The following is a description of a gene set: Hematopoietic stem cells (HSCs) have self-renewal capacity and multilineage developmental potentials. The molecular mechanisms that control the self-renewal of HSCs are still largely unknown. Here, a systematic approach using bioinformatics and array hybridization techniques to analyze gene expression profiles in HSCs is described. To enrich mRNAs predominantly expressed in uncommitted cell lineages, 54 000 cDNA clones generated from a highly enriched population of HSCs and a mixed population of stem and early multipotent progenitor (MPP) cells were arrayed on nylon membranes (macroarray or high-density array), and subtracted with cDNA probes derived from mature lineage cells including spleen, thymus, and bone marrow. Five thousand cDNA clones with very low hybridization signals were selected for sequencing and further analysis using microarrays on glass slides. Two populations of cells, HSCs and MPP cells, were compared for differential gene expression using microarray analysis. HSCs have the ability to self-renew, while MPP cells have lost the capacity for self-renewal. A large number of genes that were differentially expressed by enriched populations of HSCs and MPP cells were identified. These included transcription factors, signaling molecules, and previously unknown genes. Human Gene Set: PARK_HSC_AND_MULTIPOTENT_PROGENITORS species: Mus musculus from publication Park IK, He Y, Lin F, Laerum OD, Tian Q, Bumgarner R, Klug CA, Li K, Kuhr C, Doyle MJ, Xie T, Schummer M, Sun Y, Goldsmith A, Clarke MF, Weissman IL, Hood L, Li L (PMID 11781229) Genes commonly expressed in long term hematopoietic stem cells (HSC) and multipotent progenitors (MPP)., and this is the list of marker genes: KPNB1, PPIA, H3-3B, C5orf24, TP53, MAPK14, RPSA, P2RY4, BIRC5, BRCA2, SERF2, TTC3, SCMH1, ZNF486, VAMP5, ATP6V0E1, VEZF1, MEF2C, GDI2, CNTRL, LMO2, LY6E, SMARCE1, CCT8, MRPL4, SKP1, RNF4, ITM2B, PTMA, CDKN2D, TAGLN2, ZNF148, PSMB2, CNBP, SORBS3, TSN, CIZ1, RAMP1, KAT2A, SRSF3, SNX5, RAMP2, SEPTIN6, NAP1L4, FIZ1